The following is a description of a gene set: Thymic stromal lymphopoietin (TSLP) signaling Human Gene Set: WP_THYMIC_STROMAL_LYMPHOPOIETIN_TSLP_SIGNALING species: Homo sapiens, and this is the list of marker genes: BTK, MAPK3, MAPK9, FYN, MAPK8, CRLF2 (NCBI Gene Id 64109), TEC, NFKB1, AKT1, MTOR, STAT1, CXCL8, MAPK1 (mitogen-activated protein kinase 1), FES, JAK1 (Janus kinase 1), STAT5A, IL7R, LYN, STAT6, JAK2, IL6, STAT4, NFKB2, STAT3, MAP2K1, GAB2, RELB, RELA, MAPK14, MAP2K2, EIF4EBP1, NFKBIA, IL2RA, YES1, RPS6, MYC, CISH, HCK, CCL11, STAT5B, TSLP, LCK, SRC, PTPN11, TNFSF4